Given this list of marker genes TRPV4, SMPD3, COL2A1, RARB, SHOX2, TRIP11, EXT1, FOSL2, TSKU, ZMPSTE24, ATF2, GHR, COL27A1, AXIN2, MMP13, POC1A, TGFBR2, POR, HOXA11, CER1, SOX9, MATN1, NPPC, IHH, NPR2, COMP, COL1A1, SERPINH1, RARG, RARA, STC1, CBS, THBS3, IFT80, ENSG00000274276, here is a description of the gene set: studied in species Homo sapiens The process whose specific outcome is the progression of the cartilage that will provide a scaffold for mineralization of endochondral bones. Human Gene Set: GOBP_CARTILAGE_DEVELOPMENT_INVOLVED_IN_ENDOCHONDRAL_BONE_MORPHOGENESIS